The following is a description of a gene set: Human Gene Set: GSE2405_HEAT_KILLED_VS_LIVE_A_PHAGOCYTOPHILUM_STIM_NEUTROPHIL_24H_UP Genes up-regulated in polymorphonuclear leukocytes (24h) infection by A. phagocytophilum: heat killed versus live bacteria. from publication Borjesson DL, Kobayashi SD, Whitney AR, Voyich JM, Argue CM, Deleo FR (PMID 15879137) species: Homo sapiens Polymorphonuclear leukocytes (PMNs) were obtained from healthy individuals in accordance with protocols approved by the Institutional Review Board for Human Subjects at the University of Minnesota and the National Institute of Allergy and Infectious Diseases. PMNs (107) were combined on ice with live S. aureus (108) or with live or heat-killed A. phagocytophilum (bacteria isolated from 5x106 infected HL60 cells for a ratio of 1 infected HL60 cell: 2 PMNs, ~ 5-20 A. phagocytophilum: PMN) in wells of a 12-well tissue culture plate (pre-coated with 20% autologous normal human serum). Unstimulated control assays received either buffer (for S. aureus comparisons) or clarified HL60 lysate (for A. phagocytophilum comparisons). Plates were centrifuged at 350 x g for 8 min at 4oC to synchronize phagocytosis and incubated at 37 deg. C in a CO2 incubator for the indicated times. At the indicated times, tissue culture medium was aspirated from the plate and PMNs were lysed directly with RLT buffer (Qiagen, Valencia, CA). Purification of PMN RNA and subsequent preparation of labeled cRNA target was performed as described in Methods. Labeling of samples, hybridization of cRNA with HU133A oligonucleotide arrays (Affymetrix, Santa Clara, CA), and scanning were performed according to standard Affymetrix protocols ( http://www.affymetrix.com/pdf/expression_manual.pdf ). Experiments were performed in triplicate, using PMNs from three healthy individuals for each treatment., and this is the list of marker genes: DGLUCY, DLGAP3, DUSP11, GPATCH3, FDCSP, CAPN7, CTSD, ELOVL3, ENGASE, MTURN, CMAHP, DNAJC27, GNPAT, ENPP6, DPP3, LINC00518, ARL13B, BTNL9, GLRA3, LINC00649, CTLA4, CYP1B1, MINDY2, APLNR, BHLHA9, BATF2, C1QTNF8, CEP131 (centrosomal protein 131), AMOT, COQ10A, CILP, BUB3, ARHGAP12, ATG7 (autophagy related 7), CRIM1, GPR37, CYP4B1 (NCBI Gene Id 1580), BARHL2, CSTL1, ELAVL2, AP1S2, CDH3, CSGALNACT1, EVC2, SDHAF3, CA5BP1, ADGRG1, ASCL4, ADAMTSL4, TMA16, ATG3, GALNT3, GFRA3, EPC2, FKBP4, ACRV1, FANCB, CLEC2B, AMD1, CYP4A22, FSTL3, GABRB3, CACNA2D1, ADA, CTSF, CFAP184, CHDH, FAM209B, SUPT20H, B3GALT2, BAHCC1, DAP3, ADAT1, EOGT, CBX8, DIMT1, DDX11L2, DDX20, CMA1, FSCB, GPR12, GHDC, COPZ2, ASXL2, GLG1, CAMSAP1, ANKRD18A, DMGDH, CAMK4, CDC14A, CCND3, FA2H, EID1, CASP4, DSTNP2, BRIP1, ALKBH8, ADAM10, ASIC4, ARV1, RIPPLY3, DOCK10, FTSJ3, CDC14C, DAG1, BABAM1, ATIC, DGKK, GINS1, AMTN, CLIC3, ACAD10, ATF7IP2, FBLN7 (NCBI Gene Id 129804), DLG1, AMER2, CASP8AP2, CCDC61 (NCBI Gene Id 732172), EPB41L2, CCDC178, PHYKPL, CLTC, GP1BA, PSME3IP1, GAL3ST4, ANKRD30B, DIPK2A, UTP25, CDO1, G6PD, DDX5, CEP250, MCEMP1, BRSK2, BCAS3, C12orf75, BDP1, BMF, CNN2, ABHD17B, ALDH16A1, DRD2 (NCBI Gene Id 91906), ATP13A2, PRR30, CIRBP, ELANE (elastase, neutrophil expressed), DUT, BHMT2, LINC00898, ATG16L1, ASTL, GGTLC1, CC2D1A, GFAP, CXCL10, CCDC47, GLRA1, CARD19, CTSO, FOXF1, CALR3, CSF3R, AANAT, ATP7A, ANKH, CFAP45, ANXA10, COG3, FDXR, DEPDC1B, C22orf46P, FUT5, DLEC1, DENND2C, CYP27B1, BLOC1S1, BAG5, EFCC1, AKAP12, DMXL1, CHML, CIMIP6, EPB41, CCDC86, COX7C, DDHD1, ANXA2P2, ACVR1, DCAF8L2, GNA13, EPHA4, CTCFL, CSPP1, CAMK2A, ENPP5, TRABD2A, ADH1B, CALHM6, ALG13